The following is a description of a gene set: The process whose specific outcome is the progression of the primary sexual characteristics over time, from their formation to the mature structures. The primary sexual characteristics are the testes in males and the ovaries in females and they develop in response to sex hormone secretion. Human Gene Set: GOBP_DEVELOPMENT_OF_PRIMARY_SEXUAL_CHARACTERISTICS species: Homo sapiens, and this is the list of marker genes: CASP3, TBC1D20, CSDE1, NCOA4, NUP107, CSMD1, TSPY10, ZNF830, HMGB2, CD2AP, LHB, FANCG, OSR1, TSPY3, PTPRN, AR, WDR48, SRY, ZFY, SPO11, FOXC1, AMH, HOXA11, GATA4, BAX (BCL2 associated X, apoptosis regulator), ADAM2, MMP14, INHBB, PDGFRA, FNDC3A, FOXO3, MEA1, TFAP2C, GMNC, GFRA1 (NCBI Gene Id 2674), ZP3, DHH, TESC, GATA6, ADAMTS1, FGF9, BASP1, UTF1 (NCBI Gene Id 8433), CTNNA1, CGA, TAF4, TCF21, PLEKHA1, SOX15, INSR, KLHL10, EIF2B5, HSD17B4, SLIT3, CYP19A1, TEX11, NUPR1, GATA1, SIRT1, RRM1, MCIDAS, VGF, IDH1, GAS2, NRIP1, SFRP2, RXFP2, KIT, KIF18A, LSM14B, ADAM29, DMRT1, SLIT2, MMP2, SGPL1, SIX3, FSHR, CCND1, TSPY2, ADGRG1, LHCGR, ATM, TGFB2, ADAM21, PRKACG, CASP2, LHFPL2, ADAM32, NKX3-1, EIF2S2, NOS3, WDR19, UBB, UMODL1, RAC1, EREG, GDF9, FGF8, TLR3, WT1, CEBPB, LEP, RBMY1B, DACH2, ACVR2A, MAMLD1, ARID4B, DNAAF3, KITLG, TLR9, REC8, HOXA10, NOTCH1, ARID4A, EIF2B2, SOX9, PRPS1L1, TSPY8, AMHR2, BOK, MKKS, SRD5A2, FLNA, ARID5B (NCBI Gene Id 84159), TSPY4, CRKL, TIPARP, NCOA1, RAB13, ZFP42, BRCA2, NUP210L, H3-3B, PCYT1B, BCL2L11, ROBO2, HOXA9, NHLH2, H3-3A, RHOBTB3 (Rho related BTB domain containing 3), STAT5B, SFRP1, NR5A1, PRDX4, PTX3, ATN1, FOXL2, SALL1, REN, ODAD3, BCL2L1, WNT4, TGFBR1, ESR1, TLR5, SCAPER, RDH10, EIF2B4, GNRH1, FER, IMMP2L, ADAM18, NASP, NPR2, NOTCH4, IRX5, FSHB, NR0B1, RNF38, INHA, BRIP1, NPPC, YBX3, ING2, DMRTA1, AGO4, DNAAF11, DHX37, KDR, LRP2, FST, TSPY9, CBL, MMP19, FANCA (FA complementation group A), RETN, LFNG (LFNG O-fucosylpeptide 3-beta-N-acetylglucosaminyltransferase), FZD4, SRD5A1, GATA3, ZFPM2, CCDC182, RBP4, WNT2B, SCX, LHX9, DMC1, ABCB1, TNFAIP6, FANCE, SIX4, HESX1, VEGFA, BMPR1B, NR2F2, SOX8 (SRY-box transcription factor 8), STAT5A, ERCC1, TMF1, ADAM15, RARA, BCAS2, ATRX, ASPM, GPR149, ADCYAP1R1, DACH1, SAFB2, PGR, MSH4, AKR1C3, BIK, MSH2, HMGA2, NR5A2, TEX19, SMAD4, SPATA2, NKX2-1, PATZ1, ADAM30, HYAL3, BCL2, TSPY1, NTRK1, AFP, WNT5A, ANG, CBX2, UBE3A, CCNO, ACE, BCL2L2, CITED2, ADAM20, SOD1, INHBA